The following is a description of a gene set: Reactome Pathway: Plasma lipoprotein assembly, remodeling, and clearance Because of their hydrophobicity, lipids are found in the extracellular spaces of the human body primarily in the form of lipoprotein complexes. <b>Chylomicrons</b> form in the small intestine and transport dietary lipids to other tissues in the body. <b>Very low density lipoproteins (VLDL)</b> form in the liver and transport triacylglycerol synthesized there to other tissues of the body. As they circulate, VLDL are acted on by lipoprotein lipases on the endothelial surfaces of blood vessels, liberating fatty acids and glycerol to be taken up by tissues and converting the VLDL first to <b>intermediate density lipoproteins (IDL)</b> and then to <b>low density lipoproteins (LDL)</b>. IDL and LDL are cleared from the circulation via a specific cell surface receptor, found in the body primarily on the surfaces of liver cells. <b>High density lipoprotein (HDL)</b> particles, initially formed primarily by the liver, shuttle several kinds of lipids between tissues and other lipoproteins. species: Homo sapiens part of: Transport of small molecules, and this is the list of marker genes: NR1H3, VLDLR, SOAT2, AMN, APOA1, BMP1, APOC4, AP2A2, APOA5 (NCBI Gene Id 93561), ZDHHC8, PRKACA, CREB3L3, APOF, P4HB, A2M, LSR, RPS27A, AP2S1, APOC3, LPL, APOB, PCSK5, ANGPTL8, AP2M1, SCARB1, ABCA1, PRKACB, ANGPTL3, ANGPTL4, GPIHBP1, APOA4, MBTPS2, CLTC, APOE, SOAT1, FURIN, CES3, FGF21, NPC2, LIPG, NCEH1, LIPA, APOC2, HDLBP, CETP, PRKACG, UBC, LDLR, MYLIP, LMF1, APOBR, NPC1, CUBN, MBTPS1, APOC1, LMF2 (lipase maturation factor 2), LPA, LCAT, UBA52, PCSK6, NR1H2, CIDEC, PLTP, ABCG1, PCSK9 (NCBI Gene Id 50983), APOA2 (apolipoprotein A2), AP2A1, SAR1B, ALB, LIPC, UBB, AP2B1, MTTP, LDLRAP1, CLTA